The following is a description of a gene set: Behavior associated with the intake of food. studied in species Mus musculus Mouse Gene Set: GOBP_FEEDING_BEHAVIOR, and this is the list of marker genes: Lep, Ceacam2, Gdf15, Chrnb2, Fos, Npy2r, Cntn2, Negr1, Gpr83, Bdnf (brain derived neurotrophic factor), Uchl1, Pmch, Nmur2, Pou4f1, Prlhr, Ace2, Npsr1, Gfral, Crhr1, Uchl3, Agt, Ucn, Npb, Tbr1, Cck, Mtor, Mchr1, Nr4a3, Mmp17 (NCBI Gene Id 23948), Npy, Crhr2, Htr1a, Trh, Ntrk2, Pyy, Ube2q1, Drd1, Mc3r, Drd2, Hcrtr1, Retn, Aplp2, Oprk1, Npy1r, Qrfp, Stat3, Nmu, Insl5, Rmi1, Cfap20, Ins1, Insr, Slc24a4, Guca2b, Aoc3 (NCBI Gene Id 11754), Ppy, Htr2c, Gigyf2, Tacr1, Tmem18, Napepld, Lepr, Cyp11b2, Iapp, Hrh3, Mc1r, Bbip1, Mc4r, a, Tacr3, P2ry1, Gpr39 (NCBI Gene Id 71111), Oxt, Agtr1b, Gpr171, Ghrl, Grin1, Esr2, Derl2, Hcrt, Col6a1, Hand2, Adora2a, Ins2, Ghsr (NCBI Gene Id 208188), Cartpt, Oxtr, Dgat1, Ttc21b, Glp1r, Calca, Hcrtr2, En1, Oprd1, Ren1, Apln, Prlh, Unc79, Htr1b, Npy5r, Ankrd26, C1qtnf4, Gal (NCBI Gene Id 14419), Cpt1a, Bsx, Atp8a2, Dmbx1, Stra6, Cnr1, App, Pex13, Adrb3, Reg2, Grin2b, Bbs12, Cntfr, Cckar, Phf21a, Npw, Agrp (agouti related neuropeptide), Nkx2-1, Helt, Oprl1, Sgip1, Agtr1a, Th, Ubr3, Ace, Oprm1 (opioid receptor, mu 1), Grm7, Rxfp4, Gls, Mrap2, Ift88, Adm2, Fto, Usp46, Eif2ak4 (eukaryotic translation initiation factor 2 alpha kinase 4), Dach1